Given this list of marker genes CFC1B (NCBI Gene Id 653275), CRIPTO3, ACVR1C, CFC1, CRIPTO, here is a description of the gene set: Human Gene Set: GOMF_NODAL_BINDING Binding to a nodal protein, a member of the transforming growth factor-beta superfamily. species: Homo sapiens